The following is a description of a gene set: species: Homo sapiens The chemical reactions and pathways involving alpha-linolenic acid, an unsaturated omega-6 fatty acid that has the molecular formula C18H32O2. Human Gene Set: GOBP_ALPHA_LINOLENIC_ACID_METABOLIC_PROCESS, and this is the list of marker genes: ABCD1, FADS1, ACAA1, EHHADH, ACOT8, HSD17B4, ABCD2, ELOVL2, ELOVL1, ELOVL3, ACSL4, ELOVL5 (ELOVL fatty acid elongase 5), TMEM135, FADS2, SCP2, ACOX1